The following is a description of a gene set: studied in species Homo sapiens The chemical reactions and pathways resulting in the breakdown of diadenosine polyphosphate, a derivative of the nucleoside adenosine with phosphate groups attached. Human Gene Set: GOBP_DIADENOSINE_POLYPHOSPHATE_CATABOLIC_PROCESS, and this is the list of marker genes: NUDT4, NUDT3, NUDT11 (NCBI Gene Id 55190), FHIT, NUDT10, NUDT4B